Given this list of marker genes Ccl21f, Ccl21a, Ccl21e, Ccl21b, Ccl21d, Cd34, here is a description of the gene set: The binding of a mesangial cell to the extracellular matrix via adhesion molecules. A mesangial cell is a cell that encapsulates the capillaries and venules in the kidney. studied in species Mus musculus Mouse Gene Set: GOBP_MESANGIAL_CELL_MATRIX_ADHESION